Given this list of marker genes PAX6, NKX2-1, FGF8, SIX3, GLI3, TTC21B, GSX2, here is a description of the gene set: The formation of specific regional progenitor domains along the dorsal-ventral axis in the developing forebrain. Human Gene Set: GOBP_FOREBRAIN_DORSAL_VENTRAL_PATTERN_FORMATION studied in species Homo sapiens